The following is a description of a gene set: species: Mus musculus Human Gene Set: MEISSNER_NPC_HCP_WITH_H3K4ME2_AND_H3K27ME3 from publication Meissner A, Mikkelsen TS, Gu H, Wernig M, Hanna J, Sivachenko A, Zhang X, Bernstein BE, Nusbaum C, Jaffe DB, Gnirke A, Jaenisch R, Lander ES (PMID 18600261) DNA methylation is essential for normal development and has been implicated in many pathologies including cancer. Our knowledge about the genome-wide distribution of DNA methylation, how it changes during cellular differentiation and how it relates to histone methylation and other chromatin modifications in mammals remains limited. Here we report the generation and analysis of genome-scale DNA methylation profiles at nucleotide resolution in mammalian cells. Using high-throughput reduced representation bisulphite sequencing and single-molecule-based sequencing, we generated DNA methylation maps covering most CpG islands, and a representative sampling of conserved non-coding elements, transposons and other genomic features, for mouse embryonic stem cells, embryonic-stem-cell-derived and primary neural cells, and eight other primary tissues. Several key findings emerge from the data. First, DNA methylation patterns are better correlated with histone methylation patterns than with the underlying genome sequence context. Second, methylation of CpGs are dynamic epigenetic marks that undergo extensive changes during cellular differentiation, particularly in regulatory regions outside of core promoters. Third, analysis of embryonic-stem-cell-derived and primary cells reveals that 'weak' CpG islands associated with a specific set of developmentally regulated genes undergo aberrant hypermethylation during extended proliferation in vitro, in a pattern reminiscent of that reported in some primary tumours. More generally, the results establish reduced representation bisulphite sequencing as a powerful technology for epigenetic profiling of cell populations relevant to developmental biology, cancer and regenerative medicine. Genes with high-CpG-density promoters (HCP) bearing histone H3 dimethylation mark at K4 (H3K4me2) and trimethylation mark at K27 (H3K27me3) in neural precursor cells (NPC)., and this is the list of marker genes: C12orf56, GATA2, VAX1, CHAT, SORCS3, GJD3, CLSTN2, GALR3, RASGRF1, ACAN, PRPH, GALNT14, CITED4, ARID3C, COBL, KCNS2, CRYBA2, LTBP2, GSX1, HTR7, SYNDIG1L, SYT12, RAB11FIP1, MAL, GALNT13, AMIGO2, RERG, DPP10 (dipeptidyl peptidase like 10), XKR7, HR, WSCD2, PGBD5, ST8SIA6, STUM, OVOL2, SCN5A, SPIRE2, PTPRN2, SMOC2, HMX1, KCNQ2, GNG4, A4GALT, GABRB1, KCNA1, PTGFRN, TDRP, CACNA2D2, IRF5, GJA3, PHLDA2, RSPO1, SOX18, TBX21, OAF, CXCL14, SLC22A3, PRDM6, TRNP1, MCIDAS, BICDL1, CYP26A1, CASZ1, SPTBN2, ABCG1, CDH8, TBXT, LRRC26, NEUROD2, TLX2, VSX1, UNCX, EGFLAM, NKX6-1, PROKR2, FOXF2, CDH11, SEMA7A, KCTD8, UTF1, VIPR1, SLCO4C1, BAIAP2L1, PTF1A, WNT3A, IGSF21 (immunoglobin superfamily member 21), SALL4, HS3ST6, NOG, LHX8, GDNF, CPLX1, HOXD13, XKR4, ONECUT3 (one cut homeobox 3), DOK4, HRH3, IGFBPL1, SFRP1, CCDC92B, SCUBE3, DSCAML1, SGPP2, TP73, NKX2-4, POU4F2, EMX1, GJD2, GABRG3, JPH3, PPP2R2C (NCBI Gene Id 5522), GABBR2, KCNG3, SERINC2, STXBP5L, CRABP1, FOXD4, KIRREL2, PTPRT (NCBI Gene Id 11122), ATP2B2, SLC9A2, RTN4R, CNNM1, PLPPR3, DBX1 (developing brain homeobox 1), AHR, GHSR, CLCF1, SLC18A3, BMP8A, PRMT8, PODN, SNTG1, ZNF536, CPEB1, SLC12A5, GABRA5, WNT9B, PDGFB, TBX1, ITGA3, HOXC5, IGF2, NEFH, FOXE1, CPNE5, FLI1, MYRIP, OVOL1, PTGER3, SYT14, CELSR1, HMX2, OCLN, CRTAC1, JAG2, MMP24, KCNC4, DMRT2, SIM2, NPAS1, CBLN4, VGLL2, SHISA6, MAP3K21, DOCK8 (NCBI Gene Id 81704), NALF1, PAPPA, ISL1, FOXB2, FOXC2, ACTL6B, LAD1, VWA2, POU4F3, COL13A1, LEMD1, GJB2, ANKRD63, KCNA3, PAX2, TMEM151A, GBX1, ELAVL3, PAX1, B3GNT7 (NCBI Gene Id 93010), PAQR9, RASGEF1C, PTH2, NPTXR, PRDM16, FIBCD1, NFATC2, MSC, FLT3 (fms related receptor tyrosine kinase 3), PENK, SYNE3, FAM43B, SULT4A1, ZNF296, C1QL1, DLX3, ST6GAL2, SOWAHB, VAT1L, TMEM150C, WNT4, WNT1, CABP7, CALCR, HCN2 (hyperpolarization activated cyclic nucleotide gated potassium and sodium channel 2), C1QL2 (complement C1q like 2), RET, CADPS, SIX2, RPRML, RYR2, SCRT1, GPR27, COLEC12, TMEM163, CIMIP3, SLC26A4, ALDH1A2, SIM1, ATP6V1C2, WNT9A, MAFA, CLGN, LY6H, FAM163B, MROH5, RBFOX3, FGF3, NXPH3, NOTUM, P4HA2, LAMA1, FEV, SLC30A3, CADPS2, IHH, HMX3, HRK, KCNH1, DSCAM, ADGRB1, KCNH8, PITX1, LBX1, TBX3, OPRD1, SLC30A10, FOXD3, FAM78A, FBLL1, GNAS, SPINT1, EIF4E3, STX3, BIK (NCBI Gene Id 638), HOXA13, SCUBE1, DMBX1, ADRA2C, FOXE3, CNTN2, TGFB1, STAC2, CHRNA4, FFAR4, ATP2B3, EVX1, DLGAP2, KCNA7, RALYL, HOXD11, FOXQ1, BNC2, ASCL2, CADM3, CRHR1, FGF8, TESC, TLX1, SRCIN1, PROK2, ECEL1, FOXF1, UCN, KCNS3, NALF2, PRR16, ADAMTS2, MSX2, RGS6, AMER3, SYT2, SLC6A17, UNC5D, EVA1A, PLD5, DLX5, DNAH11, BNC1, NPR3 (NCBI Gene Id 79614), SP8, CACNA1I, HELT, ANKRD34B, IKZF3, HOXD1, FAM89A, IQSEC3, LHX6, GRIK3, DACT2, PLK5, NPAS2, NKX2-1, CDK5R2, INSM2, HCRTR1, FOXG1, KCNK1, STBD1, KCNK3, TLX3, RAP1GAP2, AFF3, MAST1 (NCBI Gene Id 22983), BMP6, LMX1A (NCBI Gene Id 4009), PARD6B, AGPAT2, TCF15, KCNK12, HCN1, AHNAK (AHNAK nucleoprotein), DMRT3, WNT6, STXBP2, RAB11FIP4, GATA6, PAX3, ALK, CDH1 (NCBI Gene Id 999), CA7, SCN4B, PHF24, TMEM132E